Given this list of marker genes Marveld3, Kank1, Ago2, C1qbp, Edn3, Itga3, Pfn2, Macf1, Ptprr, Sema5b, Crb2 (crumbs family member 2), Mapre2, Itgb7, Enpp2, Zeb2, Bmp7, Tfap2a, Ednra, Ptprg, Pkn3, Itgb3 (NCBI Gene Id 268495), Rab25, Hbegf, Adipor1, Itgb1, Zfand5, Sema6d, Folr1, Cdh2 (NCBI Gene Id 12558), Dusp10, Macir, Mmp1a (matrix metallopeptidase 1a (interstitial collagenase)), Sema3d, Radil, Ppm1f, Vegfa, Sema3c, Pdgfb, Gna12, Ret, Gdf6, Arhgap5, Nrp1, Edn1, Syde1, Dab2ip, Krt16, Acvr1c, Sema4c, Acvr1, Lrp5, Arid5b, Pten, Irs2, Cripto, Eppk1, Krt2, Sema6a, Sema7a, Sox17, Tns1, Efnb1, Rtn4, Prox1, T, Arhgap4, Fgf8 (fibroblast growth factor 8), Smad3, Akap12 (NCBI Gene Id 83397), Lama5, Vim, Spag6l, Fgf15, Mesp1 (NCBI Gene Id 17292), Ppard, Tsc2, Kank2, Epb41l5, Sema4g, Pfn1, Tgfbr1, Ager, Phactr4, Tgfb1, Pkn2, Adipor2, Sema6b, Timp1, Sema3e, Smad2, Bag4, Has1, Ccr6, Mmp2, Fgfr1, Slc8a1, Dock1, Coro1c, Cenpv, Gdnf, Epb41l4b, Dmtn, Sema6c, Cxcr4, Sox10, Arf6, Smad4, Acta2, Cd248, Gja1, Schip1, Fer, Smurf2 (NCBI Gene Id 66313), Ccn3, Mta2, Ptpn23, Wasf2, Tgfbr2, Iqgap1, Smo, Ilk, Tmigd1, Gpc3, Ric8a, Capn7, Pak3, Hyal1, Cap1, Isl1, Tac1, Src, Rac1, Akt1, Itga4, Insl3, Ptk2, Ifng, Snai1, Sash1, Pitx2, Rffl, Sdc4, Itgb1bp1, Lrg1, Fbn2, Nanos1, Amotl2, Serpine1, Scrib, Gna13, Nodal, Thbs1, Vil1, Cfl1, Tbx1, Braf, Itgb4, Prkce, Aqp1, Fgf2, Apela (NCBI Gene Id 100038489), Cxcl12, Sema3a, Pak1, Megf8, Lrp6, Kit, Clasp2, Sema3b (sema domain, immunoglobulin domain (Ig), short basic domain, secreted, (semaphorin) 3B), Plec, Wnt5a, Erbb4, Zfp640, Fut8, Ddr2, Arhgdib, Twist1, Sgpl1, Mesp2, Rock1, Ythdf3, Mmp12, Rab11a, Pax3, Sema3f, Hand2, Pkn1, Coro1a, Ptpn11, Pdlim1, Actr3, Fndc3b, Appl2, Tmem201 (NCBI Gene Id 52277), Pax6, Glipr2, Amotl1, Acvr1b, Cln3, Phox2b, Fam114a1, Evl, Tacstd2, Hdac6, Tgfb2, Prr5l, Fgf7, Il4, Ednrb, Htr2b, Irs1 (NCBI Gene Id 16367), Pip5k1a, Lamtor2, Cer1, Appl1, Cdc42, Amot, Snai2, Kitl, Bmp4, Daam2, Sox9, Clasp1, Sema4b, Plcg2, Pafah1b1, Iqsec1, Sema5a, Hyal2, Rreb1, Mtor, Fn1, Mixl1, Itga2, Apc, Anln, Plcg1, Sox8, Bmpr2, Map4k4, Actn4 (NCBI Gene Id 97354), Rcc2, Ankrd11, Lefty1, Jun, Tpbg, Nckap1, Uts2, Eng, Cd63, Pml, Shh, Nherf1, Fat2, Adam9, Calr, Mmp9, Fermt1 (fermitin family member 1), Nrtn, Nrp2, 2610005L07Rik, Gbx2, Itga11, Hif1a, Gab2, Sema4f, Tgfbr3, Fgf10, Tacr1, Cygb, Arsb, Ltb4r2, Ctsh, Dock5, Pmp22, Wdpcp, Sema3g (NCBI Gene Id 218877), Tesk1, Ovol2, Sema4d, Has2, Sema4a, Mcc, here is a description of the gene set: species: Mus musculus Mouse Gene Set: GOBP_AMEBOIDAL_TYPE_CELL_MIGRATION Cell migration that is accomplished by extension and retraction of a pseudopodium.